Given this list of marker genes Srd5a3, Me3, Selenot, Hsd17b8, Cyp2c70, Cyp2c23, Dynll1, Aoc1l3, Far2, Hsd17b1, Alox5, Duox1, Clic4, Cryzl2, Mecr, Cyp11b2, Alox8, Gpx5, Nos3 (nitric oxide synthase 3, endothelial cell), Cyp17a1, Sod2, Rnls, Ngb, Gstp2, Adh7, Hsd17b13, Aldh6a1, Vat1, Dus4l, Hsd17b2, P3h2, Ndufs8, Acad10, Coa7, Ugdh, Por, Dhdh, Cyp2c55, Acoxl, Cyb5a, Sdhd, Cyp2f2, L2hgdh, Mmachc, Cyp21a1, Hmox1, Hbq1b, Alkbh6, mt-Cytb, Blvrb, Adh5, Kdm5a, Ero1a, Sh3pxd2a, Hsd3b3 (NCBI Gene Id 99715), Gpd2, Dhrs2, Asphd2, Oxnad1, Hsd3b6, Sh3pxd2b, Fth1, Rdh1, Cox4i2, Aifm2 (NCBI Gene Id 78860), Paox, Kdm4d, Aldh8a1, Cyp2c39, Gpd1l, Fads1, Hsd17b12, Cyp1b1, Steap1, Dus1l, Gapdhrt, Prdx6, Txnl1, Uevld, Plod1, Ldha, Cyp2c65, Vkorc1, Prodh2, Fmo4, D2hgdh, Hbb-bs, Bckdhb, Mthfd1l, Nos2, mt-Nd6, Kdm4c, Gpx2 (glutathione peroxidase 2), Dld, Sardh, Dhrs9, Loxl1, Kcnab2, Ivd, Rdh11, Acox3, Idh3a, Txndc12, Cyb561a3, Lox, Ndufv1, Prodh, Gpx7, Cybb, Mthfd1, Tecrl, Cyp2c29, Dhrs3, Txndc17, Ido1, Asphd1, Cyp19a1, Cyp4a12a, Adh6b (alcohol dehydrogenase 6B (class V)), Egln3, Kdm1b (lysine (K)-specific demethylase 1B, NCBI Gene Id 218214), Srd5a2, Asph, Cyp8b1, Nox4, Rrm2 (ribonucleotide reductase M2), Chdh, Clic6, Cyp2c69, Pcbd1, Ndufa10, Aldh16a1, Cyp2b19, Cyp2a22, Gmpr2, Mical3, Alox12b, Sod1, Far1, Dhcr7, Ldhb (NCBI Gene Id 16832), Lrrk2, Kdm5d, Cyp11a1, Aldh3b2, Txnrd1 (NCBI Gene Id 50493), Ldhc, Aldh2, Hr, Hsd11b1 (NCBI Gene Id 215261), Rdh14 (NCBI Gene Id 73152), Sdr16c5, Foxred1, Fdxr, Uqcrfs1, Impdh1, Dct, P4ha3, Gfod1, Rdh7, Cyp4a32, Cyp2g1, Akr1c6, Aldh1l2, Dio2, Cryl1, Acaa1a, Cyp4a12b, Tmx1, Cyp2s1, P4htm, Dcxr, Rsbn1, Cyp2r1, Upk3bl, Pyroxd2, Sdr42e2, Dhodh, Hpdl, Akr1cl, Dus3l, P4ha2, 4930438A08Rik, Hbb-bt, Pdha2, Gsta13 (glutathione S-transferase alpha 13), Ptgis, Phyh, Gstp-ps, Chchd4, Degs1, Kdm6a, Kdm6b, Gstp3, Adhfe1, Aoc3, Gm4847 (predicted gene 4847), Cyp2d9, Cyp2j9, Cyp2b23, Egln1, P4ha1, Cbr3, Cyp2w1, Dbt, Cpox, Kdm2a, Enox2, Spr, Vat1l, Scd1 (NCBI Gene Id 20249), Dhfr, Aox1, Tpo, Cyp4f39, Hsd3b8, Gcdh, Msrb2, Cyp2j7, Fads2b, Tyw5, Miox, Aox2, Akr1b7, Sc5d, Cbr1, Mb, Cyb5r1, mt-Nd2, Cyp27b1, Sco2, Gmpr, Prdx6b, mt-Nd3, Cyp2c66, Hadh, Il4i1 (NCBI Gene Id 15088), Scd2, Cyp3a44, Kcnab1, Sqor, Tmx4, Etfa, Ctbp2, Hsd3b4, Acox2, Ero1b, Cox7a2, Fmo1, Gstp1, Alkbh2, Cyp3a59, Alox5ap, Aldh3b3, Cyp2d34, Pdha1, Ogdh, Aspdh, Gfod2, Cyp4a29, Cybrd1, Cyp2j6, Cyp2t4, Loxl3, Cyp20a1, Akr1b8, Ncf1 (NCBI Gene Id 17969), Akr1b10, Txndc5, Adi1, Aifm3, Ch25h, Hao2, Ifi30, Loxl4, Dhtkd1, Th, Plod2, Kcnab3, Loxl2, Dio1, Calm2, Cyp2j11, Acadsb, Gstm7, Dhrs7b, Cyp2u1, Ndufv2, Aldh1b1, Lao1, Clic1, Gstk1, Cygb, Cox15, Ahr, Bco1, Hsdl2, Ptgr2, Rdh13, Clic5, Glrx, Hao1, Cbr2, Hbb-bh1, Tmx3 (thioredoxin-related transmembrane protein 3), Pnpo (pyridoxine 5'-phosphate oxidase), Prdx3, Nnt, Cyp46a1, Srxn1, Impdh2, Prxl2b (NCBI Gene Id 66469), Oxr1, Nox3, Hsd17b14, Heatr4, Rsad1, Coq6, Cat, mt-Co1 (NCBI Gene Id 99197), Kdm1a (lysine (K)-specific demethylase 1A), Mdh1b, Kdm8, Glrx2, Hsp90ab1, mt-Nd5, Aox3, Cyp39a1, Pycr1, Plod3 (procollagen-lysine, 2-oxoglutarate 5-dioxygenase 3), Txnrd2, Hsd17b7, Hif1an, Ptges2, Tm7sf2, Cyp2a12, Sord, Hpgd, Cyp2b9, Cyp4f18, Gsta1, Cyb5r2, Coq7, Txn2, Degs1l, Mthfd2, Bdh2, Hsd17b11, Phgdh, Dohh, Hsd3b1, Heph, Hspbap1, Hba-a1, Sesn2, Gstt2 (glutathione S-transferase, theta 2), Smox, Pgk1, Dpyd, Kdsr, Tet1, Gpx1, Gpd1, F8, Kdm3a, Mtrr, Tyr, Noxred1, Dhrs1, Acads, Sqle (NCBI Gene Id 20775), Ndufa9, Hbq1a, mt-Nd1, Fto, Bco2, Akr1c18, Alox12, Akr1d1, Faxdc2, Gsto1, Rpe65, Maoa, Tmx2, Pycr2, Scd3, Cyp4a31, Ethe1, Gldc, Gsto2, Ncf2, Gfer, Cyp26c1, Cyb5r3, Gapdhrt2, Acadm, Tdh, Blvra, Aoc1l1, Ptges, Atp2b4, Pdhx, Mthfd2l, Fads2, Pdia4, Gpx3, Aldh1a1, Cyb561d1, Snca, Dao (NCBI Gene Id 13142), Kdm3b, Cyp2d26, Pcyox1, Ehhadh, Sesn3, Adh1, Enox1 (ecto-NOX disulfide-thiol exchanger 1), Hsd3b9, Gpx4, Ndufs4, Cryzl1, Gsr, Bbox1, Ambp, Hba-a2, Aldh1a7, Cyp3a25, Selenow, mt-Co3, Pcbd2, Cyp2c37, Cyp3a13, Akr1e1 (aldo-keto reductase family 1, member E1), Hsd17b10, Akr1c21, Kmo, Cyp2b10, Tecr, Akr1c13, Cyp24a1, Degs2, Gapdh, Mthfr, Cbr1b, Hsd11b2, Fmo5, Suclg2, Cyba, Pyroxd1, Crym, G6pdx, Gulo, Hsd17b3, Decr2, Jmjd7, Cyp2e1, mt-Nd4, Mical2, Pdgfb, Cmah, Cyp2c54, Ltc4s, Aldh3a2 (NCBI Gene Id 11672), Jmjd6, Dus2, Calm1, Ndufaf5 (NADH:ubiquinone oxidoreductase complex assembly factor 5), Uqcrh, Cyp2d12, Tet3, Pdia5 (protein disulfide isomerase associated 5), Lbr, mt-Co2, Dio3, Dhrs7l, Msra, Idh1, Akr1c12, Ptgr1, Akr1c14, Acox1, Mpo, Pecr, Fasn, Rdh10, Prdx4, Gapdhs, Nsdhl, Cyp51, Mtarc1, Ppox, Cyb5rl, Ido2, Dhrs4, Gpx8, Cyp4f13, Agmo, Me2, Rdh5, Crat, Gsta2, Prdx2, Pdia3 (NCBI Gene Id 18794), Alkbh8, Ftmt, Gm4846, Aldh4a1, Cyp2d40 (cytochrome P450, family 2, subfamily d, polypeptide 40), Aifm1, Bdh1, Cyp7a1, Dhrs11, Sdr42e1, Ndufs3, Mdh2, Pycr3, Fmo9, Rdh12, Suox, Ogfod2, Cbs, Steap4, Cyp4v3, Lacc1, mt-Nd4l, Pam, Me1 (malic enzyme 1, NADP(+)-dependent, cytosolic, NCBI Gene Id 52233), Msrb1, Ldhal6b, Alox15 (arachidonate 15-lipoxygenase), Cyp4f40, Gpx6, H6pd, Alox12e, Surf1, Jmjd1c, Ogdhl, Msmo1, Akr1c19, Steap3, Cyp4f15, Cyp2ab1, Sccpdh, Akt1, Adh4, Cyp7b1, Cthrc1, Pdia2, Mtarc2, Aldh1a2, Mdh1, Ncf4, Cyp2b13, Selenom, Uqcrh-ps1, Fmo6, Cyp4b1 (NCBI Gene Id 13120), Hbb-bh2, Rtn4ip1, Aldh1a3, Rdh8, Ogfod3 (NCBI Gene Id 66179, 2-oxoglutarate and iron-dependent oxygenase domain containing 3), Aass, Pcyox1l, Cdo1, Dnajc10, Cyp4f14, Hmox2, Aoc1l2, Alkbh7, Prdx1, Hgd, Clic3, Akr1b1, Akr1a1, Iyd, Pdhb, Moxd2, P3h1, Selenbp2, Aldh9a1, Sdhb, Kdm5c, Cyp27a1, Cyp2c67, Ptgr3, Moxd1, Pxdn, Grhpr, Ogfod1, Dhcr24, Aox4, Hbb-bh0 (NCBI Gene Id 15131), Sdr9c7, Mgst2, Rrm2b, Hba-x, Ptgs1, Fdx1, Cox7a1, Txnrd3 (thioredoxin reductase 3), Sdha, Cbr4, Ldhd, Hbb-y (hemoglobin Y, beta-like embryonic chain), ENSMUSG00000144291 (NCBI Gene Id 97167), Idh3b, Uty, Alkbh3, Mgst3 (microsomal glutathione S-transferase 3), Tet2, Alkbh5, Pir, Aldh3a1, Qsox1, Duox2, Acad9, Cyp2c50, Cyp11b1, Akr1c20, Ndufb7, Kdm5b, Dhrs7 (NCBI Gene Id 70651), Hephl1, Cyp1a1, Epx, Gstt1, Hpd, Aldh5a1 (aldhehyde dehydrogenase family 5, subfamily A1), Bckdha, Phyhd1, Cyp3a41a, Egln2, Cyp2j5, Aldh3b1, AU015836, Cyp2d10, Hibadh, Cox5a, Cyp2a4, Hsd17b4, Apex1, Wwox, Hadha, Cp, Cyp4a14, Foxred2, Acadvl, Hsdl1, Cyp2j8, Hsd3b5 (hydroxy-delta-5-steroid dehydrogenase, 3 beta- and steroid delta-isomerase 5), Ptgs2, Cyb561d2, Cyb5b, Nos1, Tdo2, Mical1 (NCBI Gene Id 171580), Tbxas1, Rdh16f2, Aldh1l1, Decr1, Ndor1, Pipox, Srd5a1, Fmo3, Sesn1, Gphn (NCBI Gene Id 70669), Dbh, Cyp3a16, Cyp3a41b, Cox6a2, Kdm7a, Frrs1, Nqo1, Pdia6, Htatip2, Tyrp1, P3h3, Impdh2-ps, Cyc1, Peds1, Idh2, Vcam1, Cyp26a1, Riox1, Pah, Dhrs7c, Idh3g, Msrb3, Cyb5r4, Cyp26b1, Cryz, Hsp90aa1, Nqo2, Cyb561, Cyp4x1, Nxn, Cyp3a57, Prdx5 (NCBI Gene Id 54683), Rdh9, Retsat, Acad8, Cyp4a30b, Aloxe3, Cyp2d11, Aoc2, Txndc2, Akr7a5, Ddo, Cyp3a11, Ndufa2, Dhrs13 (NCBI Gene Id 70451), Dmgdh, Cyp2j12, Ndufs2, Hmgcr, Cyp2c68, Fads6, Adh6a, Alkbh1, Jmjd4, Sdr39u1, Qsox2 (quiescin Q6 sulfhydryl oxidase 2), Pgd, Hsd3b2, Vkorc1l1, Kdm4a, Fads3, Fmo2, Kdm2b, Cyp2c38, Fa2h, Selenon (NCBI Gene Id 74777), Riox2, G6pd2, Park7, Noxa1, Qdpr, Txn1, Tph2, Rrm1, Selenof, Dlat, Etfdh, Cyp2d22, Alkbh4, Uox, Rdh19, Phf8, Aldh7a1, Rdh16, Lipf (lipase, gastric), Ado, Cox6a1, Cyp2c40, Nox1, Cyp2a5, Acad12, Noxo1, Cyp2j13, P4hb (prolyl 4-hydroxylase, beta polypeptide), Selenbp1, Ctbp1, Aoc1, Hsd3b7, Sdr16c6, Glud1, Cyp1a2, Calm3, Lpo, Haao, 4833439L19Rik, Scd4, Gsta5, Steap2, Kdm4b (NCBI Gene Id 224900), Gfus, Hsd17b6, Xdh, Acadl, Cyp4a10, Sumf1, Tph1, Maob, Coil (coilin), Mgst1, Acad11, Phf2, Fxn, Sod3, Aldh18a1, Acaa1b, Ndufs7, Ndufs1, here is a description of the gene set: Catalysis of an oxidation-reduction (redox) reaction, a reversible chemical reaction in which the oxidation state of an atom or atoms within a molecule is altered. One substrate acts as a hydrogen or electron donor and becomes oxidized, while the other acts as hydrogen or electron acceptor and becomes reduced. Mouse Gene Set: GOMF_OXIDOREDUCTASE_ACTIVITY studied in species Mus musculus